The following is a description of a gene set: Mouse Gene Set: chr6B2 studied in species Mus musculus, and this is the list of marker genes: Gm5305, Tcaf1, Gm7783, Gm3017 (predicted gene 3017), Gm4782, Npy, Gstk1, Gm7880, Or10ac1 (NCBI Gene Id 546896), Gimap7, Or2a25, Rpl35a-ps7, Gm18484, Gm15550, Pals2, Tmem139, Krba1, Gm35216, Or2a51, 4833403J16Rik, Sval1, Gm19172, 5430402O13Rik, Cycs, Gimap5, Gimap3, Gm18765, Gm18010, Or2f2, Arhgef5, Or2a55-ps1, Gm7887, Gm44030, Igf2bp3, Gm30781, Nobox, Gm38804, Rpl31-ps7 (ribosomal protein L31, pseudogene 7), C530044C16Rik, Gimap1, Gm19173, Gpnmb, Spmip4, Gm44764, Epha1, Mir704, Gm17060, Cul1, Gm8035, Or2a14, Sval2, Sval3, Or2a54 (NCBI Gene Id 258649), Tas2r144, Ephb6, Or2a56, Gm10242, Aoc1l1, Pip, Fam221a, Aoc1l2, Or2f1, Gm10243, Olfr439-ps1, Or2r2, Gm25161, Gm17834, Gm6352, Zfp862-ps, Sva, Rny3, Zfp282, Or2ac1-ps1, Or2a53-ps1, 1700026J14Rik, Tas2r139, Zfp777, Or2a20, 2010310C07Rik (NCBI Gene Id 72131), Or2a7, 9430018G01Rik, Gm18538, Zfp398, Ccdc126, Gm7890, Gimap6, Gm22363, Zfp783, AI854703, Gm4877, Gm35931, Gm5990, Olrf445-ps1, Gm18539 (NCBI Gene Id 100417336), Tcaf2, Tas2r143, Tas2r135, Or2a52, 4930563H07Rik, Gimap4, B230112I24Rik (RIKEN cDNA B230112I24 gene), Gm22122, Repin1, Trpv6, Or2q1, Olfr442-ps1, Rarres2, Gm27549, Tcaf3, Zfp786, Tas2r126, Kel, Zfp775, Or2a5, Gm3455, Gm34701, Fam131b, Clcn1, Or2r3, 6330419E04Rik, Sspo, Gm22939, Gm18584, Llcfc1, Gimap9, Zyx, Malsu1, Gm44262, Zfp746, Gm24348, Gm6443 (predicted gene 6443), Gm18011, Gm26289, Rny1, Pdia4 (protein disulfide isomerase associated 4), Gm7932, Gimap1os (GTPase, IMAP family member 1, opposite strand), Cntnap2, Casp2, Or9a2, Stk31 (NCBI Gene Id 77485), Tra2a, Ezh2, Mir6371, Gm16630, Or2ar1-ps1, Gimap8, Aoc1, Aoc1l3, Gm8039, Gsdme, Rbpj-ps3, Osbpl3, Or2f1b, Gm8038, Or2a12, Or2r11, Or13m2-ps1 (olfactory receptor family 13 subfamily M member 2, pseudogene 1), Tmem176a, Zfp467, Gm18007, Zfp956, Or6b1, Npvf, Gm19253, Atp6v0e2, Tmem176b, G930045G22Rik, Lrrc61, Zfp212, Trpv5, Gm5111, Tpk1, Or2a57